Given this list of marker genes GABPB1, RPS27, LPIN1, CYP4A22, IPCEF1, S100A14, VPS13D, CD3E, RBM34, PRLH, RPL36, KRI1, GGPS1, SYNE1 (spectrin repeat containing nuclear envelope protein 1), ALOXE3, CPSF7, KCNC4, EZH1, GRPR, TBC1D29P, SNRNP200, ADRA2B, MPHOSPH9, ARHGAP15, TMSB15B, ALDH3B2, RPS23, RNF144A, OR7E156P, GVINP1, NT5E, LARP7, SLC66A1, HOXB9, PRMT2, SEPTIN8, ZNF142, SPTBN1, YLPM1, OR2W1 (NCBI Gene Id 26692), AGRP, GSG1, ZFR2, ARHGAP45, ARID1A, AMIGO2, CATSPERB (cation channel sperm associated auxiliary subunit beta), ZNF264, USP11, AKR1C2, WEE1, LINC00302, TRIM15, GIMAP6, RPL30, TNKS, LDOC1, E4F1, STK38, NSMCE4A (NSE4 homolog A, SMC5-SMC6 complex component), DLGAP1, ATG4A, CYTH1 (cytohesin 1), HAVCR1, RABGEF1, PRKCH, FASN, CPSF4, CTCF (CCCTC-binding factor), MYT1L, CWF19L1, HYOU1, TARP, THPO, PGAP4, STIL, EPCAM, PMEL, AQP1, GRK6, ZNF266, RALGPS1, CCP110, PSG7, RRN3P1, PCID2, PTMA, CSPP1, HOPX, ALX1, PASK, ENSG00000290731, FRY, RPS3, ZNF75D, GFI1, AKTIP, SIK3, PCBP4, DIDO1, ABHD17A, ING1, NCAM2, SPOCK2, PLAGL2, TUBA4B, SRSF5, AUTS2, MEIS2, FLT3LG, IFITM2, ANKS1B, SLC6A16, DSG1, PEX3, PPP1R16B, CD34, TWIST1, DLG3, S1PR4, CELF2 (NCBI Gene Id 10659), ZCCHC4 (zinc finger CCHC-type containing 4), ZNF281, BCL2, GRM1, CYSLTR1, JAK1, UBAP2, RBCK1, IRF1, NAP1L3, COL14A1, FABP7, PCYOX1L, MRPL49, CCR2 (NCBI Gene Id 90262), AKT3, TPT1, MCUB, SLC38A1, GZMH, KIF21B, SIRPG, HBS1L, APOC4 (apolipoprotein C4), IL24, TM4SF1, BEX1, RNF44, ARHGEF6, CDK3, MYBL1, TRRAP, TRMT9B, GSDMB, HSPA1L, MVB12B, LPIN2, SP140, CXCR6, SMARCC2, ACKR3, STC2, PRPF19, ASB4, LPAR4, KHDC4, ANKRD27, PDLIM2, JAM3, MIA3, EDA2R, THOC2, FGF5, NMT2, PLEKHG3, ARL4C, ZNF394, SEMA4C, ZNF253, HAUS5, IFNA14, TSPOAP1, LPAR2, AZGP1, CHRNA9, ASMTL, CSK, ZEB1, STAG1, GCH1, INAVA, SAP30L-AS1, MAGEC1, ZNF711, TFAP2A, BTN3A3, PAXIP1, EEF1D, here is a description of the gene set: Genes down-regulated in comparison of dendritic cells (DC) versus effector memory CD4 T cells. Human Gene Set: GSE3982_DC_VS_EFF_MEMORY_CD4_TCELL_DN studied in species Homo sapiens In the present study we used Affymetrix oligonucleotide microarrays to produce gene transcription profiles for the major leukocyte types in humans. This comprehensive dataset enabled us to not only establish which genes were expressed in each leukocyte type, but also which genes were expressed in each subset after activation. The used of a comprehensive dataset of gene profiles from all the major human leukocyte subsets enabled a novel and powerful means for identification of genes associated with single leukocyte subsets, or different immune paradigms. from publication Jeffrey KL, Brummer T, Rolph MS, Liu SM, Callejas NA, Grumont RJ, Gillieron C, Mackay F, Grey S, Camps M, Rommel C, Gerondakis SD, Mackay CR (PMID 16474395)